Given this list of marker genes Pde1b, Pde10a, Pde1a, Pde3b, Pde11a, Pde2a, Pde3a, here is a description of the gene set: species: Mus musculus Catalysis of the reaction: nucleoside 3',5'-cyclic phosphate + H2O = nucleoside 5'-phosphate; catalytic activity is increased in the presence of cGMP. Mouse Gene Set: GOMF_3_5_CGMP_STIMULATED_CYCLIC_NUCLEOTIDE_PHOSPHODIESTERASE_ACTIVITY